The following is a description of a gene set: from publication Dudziak D, Kamphorst AO, Heidkamp GF, Buchholz VR, Trumpfheller C, Yamazaki S, Cheong C, Liu K, Lee HW, Park CG, Steinman RM, Nussenzweig MC (PMID 17204652) Human Gene Set: GSE6259_33D1_POS_DC_VS_BCELL_DN species: Homo sapiens Dendritic cells (DCs) process and present self and foreign antigens to induce tolerance or immunity. In vitro models suggest that induction of immunity is controlled by regulating the presentation of antigen, but little is known about how DCs control antigen presentation in vivo. To examine antigen processing and presentation in vivo we specifically targeted antigens to the two major subsets of DCs using chimeric monoclonal antibodies. Unlike CD8+ DCs that express the cell surface protein CD205, CD8- DCs, which are positive for the 33D1 antigen, are specialized for presentation on MHC class II. This difference in antigen processing is intrinsic to the DC subsets and associated with increased expression of proteins associated with MHC processing. Genes down-regulated in splenic dendritic cells versus 33D1+ B lymphocytes., and this is the list of marker genes: PPP1R11, GTF2H2, ITM2A (NCBI Gene Id 9452), KIF11, PPP2R1B, SPC24, PIK3CB, CCDC12, MIR16-1, NCF1, CKB, KNL1, REXO2, DNAJC27, PDCL3, SOD1, GPR141, MREG, ATP6V0E1, TALDO1, PLSCR2, AKNA, SLC46A3, AP1S3, MPPED2, NELFE, GRB2 (growth factor receptor bound protein 2), MBP, GM2A, H2BC8, TRIM11, IRF8, LY75, RPS26, RGS7, PALLD, SIPA1L3 (NCBI Gene Id 23094), GNL2, PALM, BUB1, POLR1C, ODF4, SLAIN1 (NCBI Gene Id 122060), OLFM1, CORO1A, IFI30, FIGNL1, P2RY14, SINHCAF, CS, IMMP2L, CTNNA1, FLT3, INPP5J, CD9, RAB27A, NT5C3A, KIF20B, HAUS8, TNFRSF13C, NCAPG, C9orf78, ALDH18A1, TJAP1, RPLP2, LRRC1 (NCBI Gene Id 80240), ITGAE, KCTD10, PAPOLB, SH3BP1, GTF2E2, TRIP13, H4C4, MMP25, ADAD1, RPIA, CST7, IPO4, HAVCR2, RPL15, TNFSF4, LSP1, COX6B2, MTPN, CARD11, AEBP2, LPP, GSTCD, LIMS1, TXNDC15, AP1AR, PPAT, SLK, KHK, DOCK5, RPLP1, GNG10, HMGCR, GABRB2, WDFY4, FGR, GSTP1, H2BP2, LTA4H, ATP6V1G3, IDI1, CIT, HM13, ANLN, ROGDI, MMP12, TAF7L, OSBPL3, DPP4, OTULIN, ECT2, EIF3B, H2AZ2, SORL1, GDPD5, EHMT2, TSPAN2, DOCK10, TOP2A, RNF181, BIRC5, EIF2B3, POLR2M, NONO, VASP, RALA, NOP53, NUDT1, SERF2, H2AZ1, GRAP2, TSG101, FARSA, DBN1 (NCBI Gene Id 1627), TIMELESS, TIAM1, MLH1, ADAMTS10, MIR10A, FMR1NB, KLHL36, MPDU1, GCSAM, TRMT5, MKRN1